Given this list of marker genes F2r, Sigmar1, Ndc80, Hoxd9, Phlda3, Tfrc, Fnbp1, Prkar2a, H2ax, Cbfb, Gna11, Bcl7a, Eif1ax, Rrm2, Parva, Pmp22, H2aj, Kdsr, Kank2 (NCBI Gene Id 260376), Rcc2, Mat2a, Marcks, Inip, Amotl2, Frzb, Arhgap11a, Axl, Mgat2, Slc12a2, Tnrc6a, Rras2, Sac3d1 (NCBI Gene Id 66406), Nap1l1 (nucleosome assembly protein 1-like 1), Nherf1, Pdcd4, Arl6ip4, Apln, Amot, Ccnb1, Hells, Tubb4b, Cav2, Elovl6, Pbk, Cpt1a, Usp46, H6pd, Csf1, St3gal4, Prkch, Minpp1, Srsf1 (NCBI Gene Id 70724), Cdc25a, Ajuba, Efna5, Pcmt1, Ddx39b, Hras, Tardbp, Egln1, Cdkn2c, Pycr2, Wbp1, Ddit4l, Cxcl12, Nrep, Arpp19, Lgals3bp, Gata2, Coro1c, Spast, Sephs1, Aacs, Tuba1c, Zg16, Gpx1 (glutathione peroxidase 1), Gtf2e1, Jpt1, Mapk14, Lpcat1, Kif20a, Arl6ip1, Ssh1, Trp53inp1, Cdk2ap1 (cyclin dependent kinase 2 associated protein 1), Dpp7, Ulk1, Pwwp3a, Tns1, Patj, Rbm3, Zbtb14, Amd1, Robo4, Stxbp5, Topbp1, Amd2, Setd7, Ncapd2, Atosb, Map3k11, Pkd1, Pdrg1, Ccnd1, Brd3, Crebl2, Ube2c, Aox1, Timp2, Exo1, Rpa2, Nrarp, Lama5, Arl4c, Ski, Sf3a1, Pald1, Cd81, Hes1, Dtymk, Pgam1, Pprc1, Dusp7, Ccnb2, Cryab, Nde1, Zmat3, Dok4, Nfic, Fas, Srsf7, Naip2 (NLR family, apoptosis inhibitory protein 2), Akap8, Scd2, Cbx6, Actr1a, Ssbp3, Srsf5, Cdca5, Tuba1b, Mgat4b, Rxra, Cpt2, Stmn1, Ctps1, Chst12 (carbohydrate sulfotransferase 12), Racgap1, Plec, Col4a2, Gnaq, Kpna2, Nedd4, Birc5, Ptprv, Eng, Srsf10, Cdc23, Igdcc3, Srsf2, Ubox5, Nectin3, Cd276, Ndst2, Nsl1, Chn2, Mr1, Nherf2, Hoxd8, Ramp2, Ccna2 (cyclin A2), Ncbp2, Spag5, Fam89b, Bcl6b, Crip2, Trim21, Rapgef3, Ppargc1b, Fasn, Txnip, Arrb1, Phldb2, Serinc3, Stab1, Abcg1, Pias3, Ehd4, Ifngr2, Notch1, Smo, Gart, Slc19a2, Ppm1f (NCBI Gene Id 71214), Mknk2, Map2k3, Myo1c, Ak1, Pfn2, Plxna1, Casp3, Bmp4, Dbi, Cdc42se1, Get1, Cenpa, Zfp101, Acp1, Ei24, Rgs12, Hoxb7, Pola2, here is a description of the gene set: The ternary complex factor Net/Elk3 is downregulated in hypoxia and participates in the induction by hypoxia of several genes, including c-fos, vascular endothelial growth factor and egr-1. However, the global role of Net in hypoxia remains to be elucidated. We have identified, in a large-scale analysis of RNA expression using microarrays, more than genes that are regulated by Net in hypoxia. In order to gain insights into the role of Net in hypoxia, we have analysed in parallel the genes regulated by HIF-1alpha, the classical factor involved in the response to hypoxia. We identified about genes that are regulated by HIF-1alpha in hypoxia. Surprisingly, when we compare the genes induced by hypoxia that require either Net or HIF-1alpha, the majority are the same (75%), suggesting that the functions of both factors are closely linked. Interestingly, in hypoxia, Net regulates the expression of several genes known to control HIF-1alpha stability, including PHD2, PHD3 and Siah2, suggesting that Net regulates the stability of HIF-1alpha. We found that inhibition of Net by RNAi leads to decreased HIF-1alpha expression at the protein level in hypoxia. These results indicate that Net participates in the transcriptional response to hypoxia by regulation of HIF-1alpha protein stability. species: Mus musculus from publication Gross C, Dubois-Pot H, Wasylyk B (PMID 17704799) Genes up-regulated in SEND cells (skin endothelium) at hypoxia with ELK3 knockdown by RNAi. Mouse Gene Set: GROSS_HYPOXIA_VIA_ELK3_UP